The following is a description of a gene set: DeltaFosB (a truncated form of FosB) and CREB (cAMP response element binding protein) are transcription factors induced in the brain's reward pathways after chronic exposure to drugs of abuse. However, their mechanisms of action and the genes they regulate remain unclear. Using microarray analysis in the nucleus accumbens of inducible transgenic mice, we found that CREB and a dominant-negative CREB have opposite effects on gene expression, as do prolonged expression of DeltaFosB and the activator protein-1 (AP-1) antagonist DeltacJun. However, unlike CREB, short-term and prolonged DeltaFosB induction had opposing effects on gene expression. Gene expression induced by short-term DeltaFosB and by CREB was strikingly similar, and both reduced the rewarding effects of cocaine, whereas prolonged DeltaFosB expression increased drug reward. Gene expression after a short cocaine treatment was more dependent on CREB, whereas gene expression after a longer cocaine treatment became increasingly DeltaFosB dependent. These findings help define the molecular functions of CREB and DeltaFosB and identify clusters of genes that contribute to cocaine addiction. from publication McClung CA, Nestler EJ (PMID 14566342) studied in species Mus musculus Genes up-regulated in the nucleus accumbens (a major reward center in brain) 2 weeks after induction of deltaFosB, a FOSB splice variant. Mouse Gene Set: MCCLUNG_DELTA_FOSB_TARGETS_2WK, and this is the list of marker genes: Adcyap1, Bdnf, Adarb1 (adenosine deaminase, RNA-specific, B1), Znrf2, Cln8, Txn1, Ccn2, Stmn2, Asap1, Tbr1, Cadps, Hspa1b, Syt2, Ptprk, Arhgef25, Hmgcs1, Mobp, Stmn1, Olfm1, Smad1, Ina, Fhod3, Xlr3a, Scn1a, Apba2, Ccn3, Nefh, Gars1, Inpp5j, Asic2, Nptx1, Cck, Nmbr, Tpbg, Nefm, Impact, Tubb2a, Gsto1, Cdk14, Col5a2, Septin9, Mfsd4a, Serpini1, Elavl2, Vsnl1, Fhl2 (NCBI Gene Id 96862), Coprs, Mef2c, Mgst3